Given this list of marker genes STXBP3, CADPS, CADPS2, RAB3A, STXBP1, SYT4, UNC13C, UNC13B, STXBP2, UNC13A, BAIAP3, SNAP25, here is a description of the gene set: species: Homo sapiens Human Gene Set: GOBP_DENSE_CORE_GRANULE_EXOCYTOSIS The secretion of molecules (e.g. neuropeptides, insulin-related peptides or neuromodulators such as serotonin and dopamine) contained within a membrane-bounced dense core granule by fusion of the granule with the plasma membrane of a cell in response to increased cytosolic calcium levels.